Given this list of marker genes Sf3b5, B230208H11Rik, Gm32105, C330004P14Rik, Gm18188, Gm32172, Fuca2, Zc2hc1b, Ltv1, Gm46212, Gm23892, Pex3, Gm18557, Gm7525, 4930444K16Rik, Gm8330, Gm7198, Gm5948, Hivep2, Phactr2, Nmbr, Aig1, Gm47761, Gm40604, Adat2, Gje1, Gm20125, Gm46188, Gm24343, Utrn, Gm9535, Gm8355, Vta1, Adgrg6, Stx11, Gm10335, Gm5178, Gm18039, Cited2, Plagl1, here is a description of the gene set: Mouse Gene Set: chr10A2 species: Mus musculus